Given this list of marker genes PLCXD1, NUP214, CEP170, P2RY1, HACD3, IMPA2, NEDD1, B4GALT5, SPIDR, ERGIC1, FH, TMEM135, ERH, DTD2, DNAJB14, UCP2, SLC31A2, SEPTIN10, EIF4G2, IFT57, UBE2E3, UBE2R2, SERP1, PHLDA1 (pleckstrin homology like domain family A member 1), TEX9, NT5C3A, CD47, AQP9, NLRC4, PLA1A, RTN4, S100P, RDH16, GMIP, MINPP1, MYD88, BTBD10, COQ10B, PPP1R15B, NMI, MEGF9, PLCL1, TOM1L2, GAB3, SLC39A10, SIAH2, RBM17, CD80, UTP20, SOWAHC, DDHD2, MGAT1, ELK3, OR2W3 (olfactory receptor family 2 subfamily W member 3), RHOU, PLIN2, CASP7, IL7R, DRAM2, CHCHD10, ARL2BP, RAB8B, NF1 (neurofibromin 1), CLIC1, TRIM14, MECP2, GRINA, RPIA, GSTO1, HDGF (heparin binding growth factor), NAGLU, GBP1, ME3, TAF15, LFNG, CAPN14, TLE1, DUSP1, C1orf162, HAPSTR2, IFNGR2, RCN1, TCEAL2, MRPL14, CDK5RAP1, WSB2, DCUN1D3, ACSL5, SYT17, UIMC1, THEMIS2, NHP2, BLVRB, TRNP1, PSMA6, CAP1, ITPRIP, ADI1, SLC15A3, CXorf38, PTGER2, HERC5, MRPS24, CHML, CLDN23, CISD2, RPL15, PHACTR1 (phosphatase and actin regulator 1), ZNF148, ABCC3, PDK4, RHBDL3, APOO, GABPB1, CITED2, PBX4, IL10RB, TLE3, NFXL1 (NCBI Gene Id 246220), NOCT, TLR4, ARF6, SLC6A6, SLC37A1, KSR2, IKZF1, NDUFB8 (NADH:ubiquinone oxidoreductase subunit B8), CDK18, PDLIM5, ADAM17, MFSD1, HSD17B12 (NCBI Gene Id 51144), INF2, TANK, GTF3C6, LRP5L, IFNAR2, TMEM170B, POLD4, RAD23B, EEPD1, HHLA2, IL4I1, MIR155HG, KCNA3, CRYBG1, MS4A7, PNPLA1, KBTBD7, RHOF, MARCKSL1, ANGPTL4, GTDC1, STARD4, ZBTB44-DT, FOXN2, RAB13, YWHAE, MAF, CCNG1, KLF11, STK17B, DUS1L, IL10RB-DT, HEY1, WDR54, NBN, RILPL2, CEBPD, ATP5MC2, CD36, CMPK1, MCUB, OPN3, BTG1, TFPI, FOS, DEGS1, SEMA3C, SMNDC1, CLEC2D, STK10, SECTM1, CAT, PRKACB, PHF20, ECH1, BCLAF1, TMCO6, CYB5A, FBXO38, CNDP2, NR1H3, CCDC186, FABP4, OXSR1, FNDC3B, MMD, EFHD2, here is a description of the gene set: Human Gene Set: GSE2128_C57BL6_VS_NOD_THYMOCYTE_MIMETOPE_NEGATIVE_SELECTION_DN from publication Zucchelli S, Holler P, Yamagata T, Roy M, Benoist C, Mathis D (PMID 15780994) studied in species Homo sapiens Fetal thymic organ culture (FTOC) DC2.5 CD4+CD8+ thymocytes from B6g7 or NOD background. 0 or 16 hour after addition of the BDC mimitope Genes down-regulated in C57BL6 CD4 CD8 double positive thymocyte transgenic for the BDC2.5 TCR incubated with mimetope negative sel 16h versus NOD CD4 CD8 double positive thymocyte transgenic for the BDC2.5 TCR incubated with mimetope negative sel 16h.